The following is a description of a gene set: treatment of mesenteric lymph nodes with soluble lymphotoxin-beta receptor for 0,1,2,3,27 and 35 days from publication Huber C, Thielen C, Seeger H, Schwarz P, Montrasio F, Wilson MR, Heinen E, Fu YX, Miele G, Aguzzi A (PMID 15843551) species: Homo sapiens Genes down-regulated in mesenteric lymph nodes: control versus 1 day after injection with soluble form of LTB. Human Gene Set: GSE2124_CTRL_VS_LYMPHOTOXIN_BETA_TREATED_MLN_DN, and this is the list of marker genes: RHOJ, CA7, FCRLA, PDYN, CPEB1, CCNYL1 (NCBI Gene Id 151195), TRABD, SLC25A26, PDZD11, TIFA, SPIB, UBE2F, C4orf54, PDX1, CHEK2, NMB, IMMP2L, SRL, GDNF, SPEF1, FUT10, GORAB, B3GALNT1, CCDC17, TOR1A, SUPT7L, EPPIN, ZMAT1, CCDC174, PDCD2L, MAVS, ALDH3A2, NLN, TBL2, POLG2, IBTK, ZNF341, FAM156A, VPS13C, LPIN2, HTRA2, HIGD1C, PPIP5K1, TAFA2 (TAFA chemokine like family member 2), CCDC28A, PIK3R4, SLC35A2, APBA3, YARS2, SNX33, ZNF250, ATG4D, PRKRA, SMUG1, SLC25A15, HOXB4, EPAS1, WNT5B, SKIC3, CHKA, TEDC2, PACRGL, RBM4B, PIGH, EFNB3, PPFIBP1, ZNF764, WSB2, WFDC2, GALM, OBI1, JUN, KCTD17, ZNF703, CMSS1 (cms1 ribosomal small subunit homolog), ARMCX3, PSAT1, BAG4, MANBA, LRRC14, CCNC, MFSD12 (NCBI Gene Id 60369), CCNE1, RIC1, HECW2, RNF170, KCTD6, PIEZO1, HAUS8, DNAJB9, ZNF511 (NCBI Gene Id 118472), CYP39A1, FANCM, ZFYVE16, AMY2A, GALC, TARS3, BLOC1S5, FBH1, FAM210A, NLRX1, STX19, ABCG2, NSUN6, AHNAK2, OOSP2, ABLIM3, EHD4, OSGIN2, MCTP1, MYRFL, PIKFYVE, DCUN1D3, BBS10, TRAF6, GFPT1, TM2D2, GOLT1B, CTU1, CCR5, CCDC51, GPATCH2L, MAGED1, CHMP7, TLCD2, IER3, FAM171B, CSRP2, SIPA1L3, PCOLCE2, TPD52L1, CNGA1, ZNF473, VWA8, SNIP1, PKIG, IKBIP, CCNJ, SLC4A1AP, MRPL20-AS1, GDA, DPAGT1, DNAAF9, CEP162, DCTN4, SNX10, CDC42BPG, MTHFSD, DEPDC7, ANKRD13D, ZNF48, IFT70B, CCDC68, ARL4D, DDX59, FZD5, FBP1, ACHE, RCAN1, EFHC1, SHB, ZCCHC10, PDSS1, GMEB1, MED26, COL18A1, STXBP1, EDAR (NCBI Gene Id 1898), SLC66A1, SH3D19, PLD4, DLEU7, PARD3B, EFCAB9, PKP4, ACADSB, ZPBP, STARD6, ATXN1L, MTSS2, ALOX5AP (NCBI Gene Id 241), MAGEE1, ATP13A2 (NCBI Gene Id 63919), TFEC, DDX31, RBSN, LPAR3, TDRD3, PECR, ALG11, DIO2, CRCP, TNNI3, MROH9, JMJD4, MDFIC, ARFGAP1, ANTXR2